The following is a description of a gene set: Human Gene Set: GNF2_S100A4 studied in species Homo sapiens Neighborhood of S100A4 S100 calcium binding protein A4 in the GNF2 expression compendium Neighborhood of S100A4, and this is the list of marker genes: ARRB2, COTL1, LST1, TMEM127, DOK2, TNFRSF1B, RIN3, CFP, PSTPIP1, TBXAS1, RGS2, PYCARD, CLEC4A, CCR1, HCK, FGR, TYMP, CPVL, PILRA, MCL1, CASP1, LILRA2, LILRB3, LILRA1, NCF2, GLRX, PECAM1, TYROBP, IGSF6, FCN1, GMIP, STXBP2, S100A4, ITGB2, APOBEC3A, NOD2, TCIRG1, THEMIS2, TNFSF10, SH3BGRL3, AIF1, FCER1G, FGL2, DPEP2, MYO1F, HSD17B11, LILRB2